The following is a description of a gene set: Binding to an oligopeptide. Human Gene Set: GOMF_OLIGOPEPTIDE_BINDING species: Homo sapiens, and this is the list of marker genes: PTGES, PTGES2, LANCL1, GSTM3, GSTM2, GSTM1, GSS, MMACHC, MGST2, GSTM4, FOLH1